Given this list of marker genes Cyp4a31, Cyp4f13, Cyp4f40, Cyp4a30b, Cyp4f14, Cyp4a10, Cyp4f15, Cyp4a12a, Cyp4a32, Cyp4a14, Cyp4a12b, Cyp4f18, Cyp4a29, here is a description of the gene set: Catalysis of the reaction: leukotriene B4 + O2 + reduced = 20-hydroxy-leukotriene B4 + H+ + H2O + oxidized. species: Mus musculus Mouse Gene Set: GOMF_LEUKOTRIENE_B4_20_MONOOXYGENASE_ACTIVITY